Given this list of marker genes D130043K22Rik, Tifab, Pax6, Htt, Nrxn1, Shank3, Nrxn2, Cntnap2, Stra6, Neurog1, Foxp2, here is a description of the gene set: studied in species Mus musculus Mouse Gene Set: GOBP_LEARNED_VOCALIZATION_BEHAVIOR_OR_VOCAL_LEARNING Vocalisation behavior that is the result of learning, or the process by which new vocalizations are learned.